The following is a description of a gene set: species: Homo sapiens The appearance of type I interferon due to biosynthesis or secretion following a cellular stimulus, resulting in an increase in its intracellular or extracellular levels. Type I interferons include the interferon-alpha, beta, delta, episilon, zeta, kappa, tau, and omega gene families. Human Gene Set: GOBP_TYPE_I_INTERFERON_PRODUCTION, and this is the list of marker genes: DHX58, DDX3X, ATG9A, TRIM15, CGAS, POLR3B, TOMM70, TLR7, OAS1, RAB2B, KPNA2 (NCBI Gene Id 728860), YY1, IL10, TLR3, HSPD1 (heat shock protein family D (Hsp60) member 1), CHUK, LILRA4, KAT8, TRAIP, TLR8 (NCBI Gene Id 92553), PLCG2, ARRDC4, SIRPA, GBP7, RNF26, QKI, ZC3HAV1, IRGM, SYK, ITCH, TANK, POLR3A, RIOK3, IRF1, IKBKE, CD14, DDX56, SIGLEC1, IRF3 (NCBI Gene Id 3661), PPM1B, PTPN22, STING1, OAS2, SETD2, MYD88, TRIM21, USP22, TRIM65 (NCBI Gene Id 201292), OTUD5, MIR21 (NCBI Gene Id 406991), XAF1, RNF125, HAVCR2, HSP90AA1, TLR9, STAT1, NPLOC4, MIR26B (microRNA 26b), IRF5, NLRC3, POLR3G, TICAM2, CLEC12A, IRAK1, TBK1, HMGB1, GPATCH3, PQBP1 (polyglutamine binding protein 1), IRF7, RIGI, OAS3, TRIM56, ZBTB20, GARIN5A, DTX4, TLR4, RIPK2, PYCARD, RNF135 (NCBI Gene Id 84282), CUL3, NMBR, G3BP1, TRIM38 (NCBI Gene Id 10475), XIAP, UFD1, ILRUN, CYLD, TRAF6, UAP1, HMGB2, DHX9, TYROBP, KLHL22, NLRX1, TLR2, POLR3C, PTPRS, TREX1, CACTIN, RELB, TRIM27, GAPDH, ATG5, RNF216, NMB, POLR3D, BANF1, ACOD1, TRAF3IP1 (NCBI Gene Id 26146), REL, LILRB1, FLOT1 (NCBI Gene Id 10211), MAVS, RBX1, IFIH1 (interferon induced with helicase C domain 1), IRF8, PTPN11, TRAF3IP3, POLA1 (NCBI Gene Id 5422), TIRAP (NCBI Gene Id 115469), ZCCHC3, ISG15, NMI, TRAF3, DHX33, DHX36, MMP12, POLR3F, ATG12, MORC3, TICAM1